Given this list of marker genes DAPK3 (NCBI Gene Id 1613), FUT7, PDLIM5, ST3GAL4, CD86, PLAUR, CLSTN1, DSC2, CYRIB, LAMB1, KLC1, BMP6, LAPTM5, BRD2, SASH3, ARHGDIG, VTCN1, STXBP1, CDH12, IL1RAPL1, AMBP, PTPRD, MIR183, CD34, DLG2, WDPCP, KANK1, RIC8A, AJUBA, IGFALS, SIRPG, TGFB1I1, RPSA, TNXB, ITGAL, TPM1, MIR29C, FER, SIRPB1, VMP1, ICAM5, MUC1, CWH43, SELPLG, RUNX1, TNF, MIR141, PCDHA7, PIEZO1 (NCBI Gene Id 9780), MIP, PCDH11Y, PPM1F, PLET1, FGG, ADAMDEC1, ERBB3, NECTIN4, TJP3, NCAM2, TGFBI, CLDN25, MIR503, PCDHGA7, CARMIL1, COL6A2, CERCAM (cerebral endothelial cell adhesion molecule), STRC, SLITRK2, ELFN1, HLA-DRA, CLDN6, PCDHAC2, IL4, CCR1, LAMC3, CAMSAP3, COL5A1, ITGB8, SPOCK2, ZFP36L1, CCL5, PML, ITGAV, TGM2, OMG, UTRN, FAM107A, CHST10, MMRN1, CBLL1, RSU1, INPPL1, HLA-DMB, CXCL13, FARP2, AGR2, ADGRB1, MELTF, SERPINF2, PCDH19, MEGF11, AATF, CCN5, ABI3BP, PSEN1, NOTCH1, CIROP, FUT2, APLP1, PSG5, DUSP1, ZFHX3, SIPA1, VCAM1, NEGR1, PCDHA13, COL6A5, RAB10, CLCA2, SOX13, TGFB2, ACHE, PIK3CB, CD37, NKAP, CTTN, CDH17, HLA-DRB4, CLASP2, ADA (adenosine deaminase), SRPX, NPHP4 (NCBI Gene Id 261734), TENM3, STXBP6, FN1, GOLPH3, ANGPT1, ARID1B, NEXMIF, PLEKHA7, SFRP2 (secreted frizzled related protein 2), AKT1, IZUMO1, SPINK5, BCAR1, KIT, VNN1, ACTG1, PTPN1, VAV1, SLC39A8, OLR1, GFUS (GDP-L-fucose synthase), CDH15, PDPN, PCDHGB5, ADGRL3, PCK1, CNTNAP1, CHL1, CDH13, NFASC, BCAN, FADD, DDR2, IL10, MYH10, KIFC3, JCAD, STX3, LPP, MMP14, CCN2, ADAM8, FES, PCDH20, ITGA7, MAD1L1, RASAL3, ACVR1, PCDH15, ADAM17, FSTL3, ITGB1, ITGB3, TROAP, FGA, ITGBL1 (integrin subunit beta like 1), AMBN, NLGN4X, IFNA2, IL7R, HBB, ANOS1, ADAM12, PRKCQ, SELL, BMP5, TIMM10B, CXCL8, COL5A3, COL8A1, F11R, ONECUT2, ARHGEF7, ICAM4, GP1BA, LAMB2, CD3E, CLDN5, CNTN2, NINJ1, ICOSLG, LAMB3, SCN1B, ERBB2, VIT, LAMA4, RREB1, ALCAM, TNFSF11, JAM2, CLSTN3, LGALS9B, LRRC4B, MIR10A (microRNA 10a), THEMIS2, TJP2, FAT3, CADM2, PTK7, PPP1R12A, PARVA, PCDHGA12, NRXN3, HAS1, PTPRO, ZC3H8, ROCK1, CASS4, IL1RAP (NCBI Gene Id 3556), CBFB, FUT3, PARVB, ARID2, ASTN2, PLA2G2F, THBS3, CXCR3, PCDHB5, NPY2R, NPTN, PXDN, MIR222, XG, CNTNAP5, APOA1, NRXN1, LILRB1, PIK3R6, NTN4, PVR, ACVRL1, ITGA2, SLK, PLXNB2, PRDX2, SGCE, SIGLEC9, DEFB118 (NCBI Gene Id 117285), CDH19, ITGA5, CDH22, CRKL, CSTA, PPP3CA, NDFIP1, CNTNAP3B, BOC, PTPRF, RHOH, WNT4, NDNF, DOCK1, LAX1, ITGA2B, ALOX5, MYL12A, IFT74, MMP24, CCL4, ATP4B, BMP2, SMARCB1, NF2, CFL1 (cofilin 1), PCDH12, TNFSF14, OLFM4, RIPOR2, WASHC2C, LOXL3, MIR30B, HFE, SSPN, EPB41L5, CCR7 (NCBI Gene Id 1236), HLA-A, THBS2, CDHR1, IL4R, CLDN2, PCDHGA8, MIR138-1, ACTN1, FYN, IL6ST, NEXN, FREM2, PCDH17, GLMN, BCAM, ACTN2, NEO1 (NCBI Gene Id 4756), GRID2, DSC3, RADIL, CALR, FOXC2, LRRC32, CRB1, SLC9A1, CLDN4, KIRREL3, PCDHA4, EPHA2, CCL21, CLECL1P, CASK, CD6, LRFN5, SCARF2, NCAN, CGREF1, MIR939, CD33, PTPRU (NCBI Gene Id 10076), CBLB, PCDHAC1 (NCBI Gene Id 94938), EFNA1, PCDHGB2, PSG11, STRCP1, TMEM131L, SDK2, MIR27B, ATP1B2, SELENOK, MYOC, MYL9, HOXD3, RGCC, ADAM2, S100A9, RASGRP1, MACF1, PTPRR, ITGA8, CD28, CLDN20, CDHR4, RHOB, PCDHB8, CD151, HSPB1, SOCS5, PCDHGB3, LRRC7, GCNT2, CHST4, PERP, TRPM7, PTPRG, CCN3, LIMS2, PTPN23, CDH4, ANK3, IGSF11, CD69, VAMP3, PPFIA2, COL17A1, SPECC1L, CLDN34, PLA2G2D, NTNG2, CDK6, CELSR2, PRKG1, CDH20, IL2, OMD, APOD, ZP4, HLA-DQB1, PPIA, DST, RAG1, FZD7, ACTB, CYP1B1, MERTK, PCDHB9 (NCBI Gene Id 56127), APP, ICAM1, CLDN3, NFKBIZ, FOXO3, CPLANE2, IGFBP7, CLDN1, PCDHB12, PIP5K1C, DUSP3, MIR125A, S100A8, CLDN19, NTN1, RUNX3, CLASP1, CIB1 (calcium and integrin binding 1), SDK1, NPNT, MPZL3, VWA2, IL4I1, DAB2, CYTH3, TECTA, CD46, SPI1, PLA2G2A, TSC1, HTN1, COL14A1, DSCAM, JAK1 (Janus kinase 1), SEMA3E, CHRD, BCL2L11, MARCHF7, COL8A2, LRRN2, LIMCH1, FREM3, ROPN1B, SHH (sonic hedgehog signaling molecule), SELP, CFDP1, CORO2B (NCBI Gene Id 10391), NECTIN2, SMARCD3, SIGLEC12, DPP4, CLDN8 (NCBI Gene Id 9073), ITGA10 (integrin subunit alpha 10), HAPLN1, FLNA, PIK3CD (NCBI Gene Id 5293), ASTN1, DUSP10, UMOD, YES1, ANTXR1, MUC21, TMIGD2, COL19A1, EFNB3, CD96, HLA-DOB, YWHAG, PCDHGA6, TRO, PAG1, FAT4, PECAM1, PRKY, FBN1, SIGLEC5 (NCBI Gene Id 8778), PRNP, DNAJA3, RAC2, RIPK2, ABL2, NF1, MCAM, PPP1CB, CD36, NLGN2, CR1, EMP2, IL1B, CD24, AMIGO1, PCDHB7, FOLR1, KAT5, PCDH10, PCDHA2, EFNB2, GP1BB (glycoprotein Ib platelet subunit beta), COL6A1, IGF1, RPS3, PCDHA9, TM9SF4, FLRT2, PTK2, NR5A2, ACTL6B, RAC1, RRAS, TMEM8B (NCBI Gene Id 92973), CD44, RAP1GAP (NCBI Gene Id 9676), TNFSF9, IL21, EPO, PKD1, DPT, CCL25, HLA-DMA, PLXNC1, SNED1, LRRC4, RBPJ, DLG3, FGL1, GLI2, NID2, IL20RB, TPBG, PSG2, TRIP6, CD47, POSTN, TSPAN32, FCHO1, LRFN3 (leucine rich repeat and fibronectin type III domain containing 3), CITED2, CD58, ESAM, GATA3, ITGAD, PGM5, JAK2, STAB1, NEDD9, S100A10, DSG2, XCL1, KLF4, CRB2, LSAMP, PRKCZ, CCR2 (C-C motif chemokine receptor 2), AXL, SFRP1, CDH6, PRKAR1A, PCDHGA11, SLITRK5, CEACAM6, CLDN7, MADCAM1, B4GALNT2, CEBPB, GREM1, COL4A6, UNC13D, CSRP1 (NCBI Gene Id 1465), CD70, DCHS1, APOA4, PDLIM1, ADAMTS13, TJP1, MMP12, COL26A1, GLDN, IRF1, CLDN9, CADM4, LMO7, SEMA5A, STON1, ADAM18, NCAM1, DOCK8, AMBRA1, NCKAP1L, P2RY12, CDH9, DMTN, GRHL2, ADAM9, CCN1, MALT1, TNFSF4, SMAD3, SORBS1, LAMC2, LGALS9, VEZT (vezatin, adherens junctions transmembrane protein), PKP2, CD200, SOX2, LEF1, AP3D1, CCDC80, PSTPIP1, CRK, MFSD2B, SH2B3, NME2, ITGA9, HTR2A, CTNNAL1, PRKCA, ARPC2, SIGLEC6, CD74, ITGA6, TARM1, ISLR, EGFR, CCL19, MSN (moesin), THY1, PODXL, SMARCE1, CASP3, ITGA3, DMP1, CSPG5, CD84 (NCBI Gene Id 8832, CD84 molecule), PXN, TRAF6, MXRA8, HAPLN4, SCRIB, BCL10, EPHB1, CCN4, CTSG, AKNA, PYCARD, SPON2, SLURP1, RC3H1, DLG5, TFRC (transferrin receptor), BSG, LGALS2, PDCD1LG2 (programmed cell death 1 ligand 2), JAG2, TMEM47, EGFL6, PLXNB1, CYFIP2, XBP1, PCDHGA10, BTN2A2, GPR65, B4GALT1, EXT1, CDK5R1, RAC3, ALOX12, MTSS1, LGALS3 (galectin 3), ILDR2, PLG, RET, MIR221, EPHA7, TOR1A, PCDHGB4, CDH24, SMAD6, LGALS3BP (NCBI Gene Id 3959), NR4A3, MYBPC2, KITLG, FOXA2, NINJ2, PCDHB2, ARID1A, TNN (tenascin N), CCL28, C1QTNF1, C1QBP, SLITRK1, CXCR4 (C-X-C motif chemokine receptor 4), ENTPD1, HSPD1, HSD17B12, L1CAM, RCC2, CDC42EP1, TIGIT, TGFB1, KLRK1, HES5, FAF1, HLA-G, PARD3, LILRB4, ITGB3BP, MIR27A, FBLN1 (NCBI Gene Id 2192), SIRPA, MAP2K1, FGL2, MSLNL, SIGLEC14, DENND6A, PDPK1, MYO10, CNTNAP3, AFDN, CLEC4A, LIMS1, SMARCD1, ZC3H12A, S100B, SKAP1, PCDHGC4, PCDHB6, FERMT1, DAG1, CLDN17, ARG1 (arginase 1), RDX, CD63, SEMA6A, PPARA, SDC4, KIF14, TINAG, ROBO1, COL18A1, MIR31, WNT3A, VAV3, TACSTD2, TRIM29, SART1, PRKX, AMTN, ARHGAP5, RNASE10, KDR, PDIA3, ELFN2, ADAMTS18, SIGLEC11, GPR4, CHST2, TYRO3, SORBS3, PTPRA, METAP1, KLHL25, MAG, ZDHHC2, CD83, AOC3, PLEKHG4B, TBCD (NCBI Gene Id 6904), PCDHB14, SRPX2 (NCBI Gene Id 27286), MDK, MYF5, KRT18, MYBPC3, PCDH1, PAWR, STX4, SMARCC2, NODAL, TMOD3, APC (NCBI Gene Id 324), CLDN24, CCN6, LRP12, CTNNA3, TEK, CD160, ROBO3, CDHR2, UNC5D, WNT7B, TYK2, IGSF5, FGFRL1, SRC, BRD7, LYPD3, MAGI1, DOCK5, ZBTB16, PCDHGA4 (protocadherin gamma subfamily A, 4), P4HB, FUT1 (NCBI Gene Id 2523), OPA1, SPRY4, ITGB4, CLSTN2, CEACAM8, AMELX, LAMA5, LILRB2, DSG1, IL6R, SLC7A1, ITGAM (integrin subunit alpha M), KLRC4-KLRK1 (KLRC4-KLRK1 readthrough), ITGB5, WNT5A, FOXP3, LCK, MIR128-1, BAIAP2L1, PDGFRA, SOCS1, DNAJB6, SIGLEC1, PNN, SCGB1A1, ARVCF, WNT10B, NFAT5, TUBB1, CLDN11, EPB41L4B, CLDN10, PKP1, ZDHHC21, CYLD, MYH9, HMCN2, DSCAML1, PPFIA1, BRD4, FAT2, GAS6, LGALS8, TNFSF18, ITCH, GP5, MIR146A, STAB2, CDH11, HSPH1, SYK, CRTAM, LGALS4, COL15A1, COL6A6, IL1RN, BAD, UFL1, BAIAP2 (NCBI Gene Id 10458), FIBP, EGR3, SOX9, BMP10, ERBIN, EBI3, TWSG1, LGALS7B, PAK4, POLDIP2, PCDHB13, IL23R, ANXA2, FNDC3A, ICAM2, PLPP3, ENG, HRG, GPNMB, EGFL7, ITGA1, TNFRSF13C, MIR9-1, ICAM3, EFS, MAP2K5, IL18, JAG1, EFNA5, CADM3, SPAM1, EZR, ELANE, LAG3 (NCBI Gene Id 3902), PHF10, CD93, ACER2, DACT2, PTPRS, CARD11, PTK2B, ADGRE1, RELA, FERMT2, NRARP, ABL1, SERPINB8, LAMB4, MFGE8, ANGPTL3, OPCML, LRP5, ARHGAP6, HLA-DPB1, PCDHB4, CDH23, BST1, SPACA4, PLA2G5, ANGPT2, FYB2, MYOT, PKD1L1, SIGLEC7, MIR181C, GATA5, FBLIM1, HLA-DPA1, MPZL2, SSX2IP, S100A11, DAB1, CLDN14, IL1A, MIR519D, SPARCL1, PCDHB3, RPSA2, FXYD5, CEACAM1, C2CD4B, HHLA2, PCDH9, ITGAX, EPHA4, FUT4, SLAMF1, COL7A1, ADAMTS12, AP1AR, MMRN2 (multimerin 2), TBX21, AGGF1, HAPLN3, CX3CL1, CDH10, DCC, PTEN, FBLN2, CLDN15, HLA-DQA2, PCDHGA5, KIRREL1, HLA-DQB2, CDHR3 (NCBI Gene Id 222256), MYBPH (myosin binding protein H), CD300A, RND1, HMGB1, MYPN, IHH, GATA1, CSF3R, MAP3K8, CD22, ITGB7, EPDR1 (ependymin related 1), MICALL2, BLOC1S4, NLRP3, FOXF1, VWF, SMARCD2, PCDHGB1, ZP3, CDH16, CD164 (NCBI Gene Id 8763), ROBO4, IGFBP2, HSPG2, ADAMTS9, ARF6, ADGRV1, ICOS, METTL3, SMARCA4, NLGN1, CDC42, MIRLET7G, EPHB3, ADAM23, ASS1, CD9, VSIG10L2, CCR3, TLN2, HYAL1, ROCK2, THBS4, PKHD1, SYMPK, LMLN, CLEC4M, CDH3, HEPACAM, FOLR2, PTPRK, COL4A3, NRG1, PTPRJ, IFNL1, CLDN22, SLC7A11, FBLN7, GCNT1, BGLAP, IL7, DSC1, SLC4A2, SRCIN1, STAT5B, JAM3, MBP, MIR675, RAB1A, CD209, FLRT1, COL13A1, IRAK1, PARD3B, RHOA, FLOT1, PCDH7, DSG3, SHC1, PTPN11 (NCBI Gene Id 84990), ITGB1BP1, TTYH1, HLA-DRB5, PBXIP1, HES1, PLXNB3, MDGA1, NRXN2 (neurexin 2), NECTIN3, ADAM15, C2CD4A, LRG1, PRICKLE1, ADD2, FBXO38, CSK, PCDHGA3, PTPN22 (protein tyrosine phosphatase non-receptor type 22), TMIGD1, S1PR1, NUAK1, CNTN3 (NCBI Gene Id 57632), CELSR1, SIGLEC10, CXCL12, TMEM102, FOLR3, DLG1, CELSR3, CDH18, TNFRSF18, PKN2, CDK5, PPARD, ATP2A2, EPHB2, PTPN6, CLDN23, CD55, PARVG, PCDHB11, PRKD2, BCL2, SLC6A4, ZYX (NCBI Gene Id 7791), CDH8, SAA1, PDGFB, PCDH8, ACTN4, MFAP4, PTPRT, HABP2, LY9, SPTA1, GBP1, GPM6B, COL16A1, DAPL1 (death associated protein like 1), CBLN1, AJAP1, LDB1, PDE3B, EPHA3, MYBPC1, SOX12, IL2RA, APBB1IP (amyloid beta precursor protein binding family B member 1 interacting protein), IL12A, CORO1A, CCDC88B, HLA-DRB3, CD1D, PCDHGA2, RASA1, THSD1, SMAD7, EPHA8 (NCBI Gene Id 2046), CADM1, ZNF703, NPHP1, MIR21, PDZD2, RAG2, CSF1, PLEK, PCDHA1, YTHDF2 (YTH N6-methyladenosine RNA binding protein F2), COL3A1, MYO1G, CD226, PKP4, MIR92A1, PPFIBP1, CALCA, EPHB4, CBLL2, PCDHA10, FAP, IGDCC4, ECM2, PNP, TNIP1, ZAN, MEGF10, DGCR6, ACAN, IFNB1, MSLN, RIN2, ANXA9, HAPLN2, NRCAM, CTNNB1, ONECUT1, VSIG4 (V-set and immunoglobulin domain containing 4), ROBO2, GTPBP4, TSPAN9, PCDHB18P, VTN, STXBP3, CCR8, PCDHGA9, AMIGO2, IGF2, HLX, CDH26, TNFAIP8L2, WNK1, SMARCA2, AKIP1, SRF, PBRM1, RC3H2, BRAF, PHLDB2, MIRLET7E, ACTL6A, ETS1 (ETS proto-oncogene 1, transcription factor), OTOA, BHLHA15, CTNNA2, SSPOP, PLXND1, ATXN3, RAP2B, HAS2, CX3CR1, TNC, IGSF9B, SMARCC1, GP6, SOX4, VEGFA, PTPRC, BMP7, IL36B, CLIC1, CD2AP, KIFAP3 (NCBI Gene Id 22920), PELI1, WHAMM, CELA2A, PKP3, B2M, IL1RL2, AZGP1, NT5E, PRSS2, TENM2, ITGB6, HLA-DQA1, HLA-DRB1, PCDHB1, CCL11, DCHS2 (dachsous cadherin-related 2), CDH5, SCARF1 (scavenger receptor class F member 1), CNTN5, MPZ, FRMD5, MINK1, PCDHGB6, TESK1, IL12B, RHOD, PCDHB10, TFE3 (transcription factor binding to IGHM enhancer 3), PEAR1, EGFLAM, CORO1C, LGALS9C, ATM, CDH7, PREX1, AGER, ZBTB1, STAT5A, TNFSF13B, BCR, PRLR, TNFRSF12A, DGCR2, DLG4, SIGLEC8, PCDHGA1, TNFRSF21, PCDH18, SFN, SLITRK3, ITGA11, CD274, PCDHA3, PDIA2, SFTPD, COL1A1, PTPRM, CUZD1, TNR, CNTNAP2, CCL2, ZMIZ1, IGSF9, VCAN, TAOK2, LIF, PCDHA6, MTOR, VSIG10, AZU1, TIAM1, CD276, LGALS1, DISC1, NFKBID, TESC, LYN, HOXA7, CDHR5, CTLA4, CD4, NTM, RS1, BMI1, PRKCE, CDSN, BTNL2, ADAM32, PCDHGC5, SUSD5, IL12RB1, DUSP22, ITGB2, CLDN18, FAT1, ABCA12, AMIGO3, GSK3B, PRKAA1, ILK, NRP2, FLG2, ADIPOQ, EDIL3, EPHA1, EFNB1, TMX1 (thioredoxin related transmembrane protein 1), COMP, SELE, ZAP70, DHPS, CYTH1, ADAM19, ASTL, CLDN16 (NCBI Gene Id 107986170), ATP5F1B, TESPA1, NPHS1, CD81, DSG4, ITGAE, SERPINE1, DUSP26, LAMC1, MYADM, NID1, BMP4, IL2RG, PCDHGB7, LYVE1, PIK3R2, KNG1 (NCBI Gene Id 589), MAEA, CXADR, CDKN2A, ACTN3, ATP1B1, PCDH11X, TRPV4, CNTNAP4, FLRT3 (fibronectin leucine rich transmembrane protein 3), SNAI2, PPP1CA, ACKR3, DDR1, CLDN12, PCDHGC3, IFNG (NCBI Gene Id 3458), GNAS, SPINT2, CEACAM5, SERPINE2, CD40LG, RELL2, ADORA2A, CTNND1, BVES, CAV1, STK10, REG3A, TENM4, MUC4, MAPK14, FZD4, HACD1, KIRREL2, BCL6, SPOCK1, KLHL22, CRNN, EFEMP2, COL6A3, DSP, PCDHA8, IDO1, PCDHA5, MKLN1 (muskelin 1), CTNNA1, NPY, NCK2, ADAM22, IBSP, PCDHA11, SOCS6, LRRC4C, RARA, CTNND2, LAMA1, ITGA4, PRPH2, PLEKHA2, MMP2, ADGRG1, ARL2, GP9, CD200R1, CD5, GPC4, DTX1 (NCBI Gene Id 1840), PRTG, TESK2, SPN, PLAU, TNFAIP6, AIF1, FPR2, PIP5K1A, MUC16, ZBTB7B, CD99, SWAP70, SLAMF7, CYTIP, IL6, MIA3, RGMB, SHB, BMX, LAMA3, PIK3R1, LEP, SLC23A2, HMCN1, FEZ1, DLC1, CD80, CD99L2, ADGRE2, NTNG1, BTLA, ADGRE5, VPS33B, LAMA2, FREM1, ITPKB, AP3B1, EPCAM, FBLN5, PODXL2, FUT9, FERMT3, VWC2, PALLD (NCBI Gene Id 51653), TLN1, CD177, UBASH3B, FOXJ1, MAPK7, NLGN3, JAK3, EP300, SVEP1, APBA1, SEMA4D, CNTN4, HLA-E (NCBI Gene Id 3133), SPP1, NCK1, PCDHB16, GNRH1, VCL, SRGAP2, RTN4, MIR192, MOG, HPSE, TRIOBP, SIGLEC16, DLL1, TNFRSF14, CNTN1, CNN3, IL32, COL12A1, NOTCH4, IZUMO1R, GLI3, HCK, EMILIN1, ROM1, NECTIN1, BAG4 (NCBI Gene Id 9530), LRFN4, IL15, COL28A1, LRP6, FGB, JAML, RND3 (Rho family GTPase 3), THBS1, RELN, ATP2C1, CD72, PTPN2, IGSF21, F2RL3, MAP4K4, SPON1, NOD2, CDH2, ADTRP, PRKCD, ANXA1, LPXN, JUP, MAD2L2, CLEC4G, HAVCR2, EDA, EMILIN2, PEAK1, ALOX15, LY6D, CNTN6, VSIR, FLOT2, WNT1, PIK3CG, CDH1, ASCL2, NLGN4Y, PCDHA12, ADAM10 (ADAM metallopeptidase domain 10), EMB, CD27, STK4, IGDCC3, KIF26B, HLA-DOA, CDON, ARG2, IL23A, GPAM, NRP1, PCDHB15, TGFBR2, CD2, PDCD1, FOXA1 (NCBI Gene Id 3169), here is a description of the gene set: The attachment of a cell, either to another cell or to an underlying substrate such as the extracellular matrix, via cell adhesion molecules. Human Gene Set: GOBP_CELL_ADHESION studied in species Homo sapiens